Given this list of marker genes TRIM46, ANK3, CNTNAP2 (contactin associated protein 2), COPE, EPB41L3, CNTNAP1, CNTN2 (contactin 2), UGT8, MAL, COPA, here is a description of the gene set: Human Gene Set: GOBP_PROTEIN_LOCALIZATION_TO_AXON A process in which a protein is transported to or maintained in a location within an axon. studied in species Homo sapiens